Given this list of marker genes Aldh8a1, Cybrd1 (NCBI Gene Id 73649), Gabrg2, Klhl9 (NCBI Gene Id 246693), Dbndd1, Cimap3, Sidt1, Rae1, Pdzd8, Pcdhb15, Clic5, Adam11, Maml1, Atf2, Ski, Ubqln5, Slc24a3, Soat1, Igdcc3, Gpx3, Dhx37, Gspt1, Fchsd1, Epha8, Trem6l, Fhip2b, Creb5, Ube2ql1, Tnfsf8, Dcaf7, Col27a1, Kprp, Pcm1, Nat8l, Vps50, Tmem86a, Map1a, Hook1, Lrrc8e, Arhgef25 (NCBI Gene Id 71969), Pld4, Spout1 (SPOUT domain containing methyltransferase 1), Slf2, Tspan9, Rps6ka2, Iqck, Susd6, Map3k12, Ttn, Syt1, Nek6, Stx1a, Adarb2, Sox7 (SRY (sex determining region Y)-box 7), Sidt2, Fut10, Itga4 (integrin alpha 4), Acss2, Kmt2a, Cnp, Cpeb2, Ucn, Ubald2, Prx, Foxc2, Cyth1 (cytohesin 1), Basp1, Slc8a3, Grm1, Srpra, Coro2b, Mmp2, Naip6, Pcbp4, Fndc3b, here is a description of the gene set: Genes predicted to be targets of miRBase v22 microRNA mmu_miR_6998_5p in miRDB v6.0 with MirTarget v4 prediction scores > 80 (high confidence targets). species: Mus musculus from publication Chen Y, Wang X (PMID 31504780) Mouse Gene Set: MIR_6998_5P